The following is a description of a gene set: Catalysis of an oxidation-reduction (redox) reaction in which NADH or NADPH acts as a hydrogen or electron donor and reduces a hydrogen or electron acceptor. Human Gene Set: GOMF_OXIDOREDUCTASE_ACTIVITY_ACTING_ON_NAD_P_H species: Homo sapiens, and this is the list of marker genes: NDUFV2, CBR3, CYB5R2, NDUFS2, CYBA, MT-ND6, AIFM1, TP53I3, AKR1C1, CYB5R4 (NCBI Gene Id 51167), NDUFC2, NDUFA6, NOXO1, CRYZ, NNT, NCF4, NDUFB6, NDUFB9, MT-ND4L, MT-ND4, SH3PXD2A, NCF1B, DUOX1, NDUFA8, NDUFB10, AKR1C3, AKR1C2, AKR1C4, RNLS, NDUFB7, CBR4, ADH4, NDUFA2 (NCBI Gene Id 4695), NOX4, FMO5, NDUFA1, NDUFB3, MICAL2, NOXA1, MT-ND5, NOS3, NDUFS3, NDUFA10, CYB5RL, NDUFS8, NDUFS1, RTN4IP1, NDUFA9, AGT, NDUFS7, MT-ND1, CBR1, CRYZL1, CYBB, PYROXD1, NOX5, ENOX1, NDUFB8, SH3PXD2B, NDUFB2, NDUFS6, NDUFB5, POR, MT-ND3, MIOX, AIFM3, NDUFA4 (NDUFA4 mitochondrial complex associated), NQO2, NDOR1, NDUFV1, AMBP, NCF1C, COX15, NDUFS4, DHRS4, NCF2, AIFM2, MTRR, NDUFA5, KMO, NCF1, DCXR, NDUFV3, CYB5R1, NDUFB1, NDUFS5, MT-ND2, NDUFB4, NOX3, DUOX2, NOX1, CYB5R3, NDUFA7, NDUFA12, NDUFA3, NDUFC1, MICAL1 (NCBI Gene Id 64780), NQO1, PDGFB